The following is a description of a gene set: Human Gene Set: GOCC_DENDRITIC_TREE species: Homo sapiens The entire complement of dendrites for a neuron, consisting of each primary dendrite and all its branches., and this is the list of marker genes: BSN, AMIGO1, NPFF, CALB1, KIFC2, SHANK3, ABHD17C, RARA, FZD4, TRIM3, CNIH3, RACK1 (NCBI Gene Id 90938), TANC1, PAK1, GLRB, KCNH1, HTR2A, ATCAY, PPP1R9B, KCNB2, DAB2IP, GRIN2A, SARM1, IGF2BP1, KCNIP2, APBA2, TP63, DAGLA, LGI1, DGKI, DRP2, RGS12, TMEM266, SLC32A1, CHL1, CHRNA4, NR1D1, FEZ1, DIP2A, RHOA, TRPV1 (NCBI Gene Id 7442), GABRE, SYAP1 (synapse associated protein 1), TMEM222, EPHA8, CX3CR1, AKAP5, HTR7, CDKL5, BRINP2, RGS7, THY1, FCGR2B, BRINP3, ZDHHC5, MAST1, TNN, DBNL, BDNF, NECTIN1, KCNJ2, OPRM1, GABRA2, SLITRK2, PLEC, APOE, EPHA10, RGS8, ADORA2A, DHX36, OPRD1 (opioid receptor delta 1), C4A, SHISA9, STAT1, GIGYF2, SKOR1, RTN4RL2, FUBP3, SYN1, STRN4, RGS14, ATP2B2, HIP1R, AKAP9, EPHA4, FXR1, CLU, GAP43, SLC12A5, MME, GLRX5, CRHR2 (corticotropin releasing hormone receptor 2), SRGAP2, HTR1D, STRN, NRGN, KCND1, SOD1, GABRA4, ADORA1, BECN1, COMT, PLK3, PALMD, SYT11, ATP1A2, MARK2, OPA1, SRCIN1 (NCBI Gene Id 80725), PCDH8, CACNG3, NCS1, PRSS12, DTNBP1, RAB5A (NCBI Gene Id 5868), VSTM5, FZD3, LRIT1, XRN1, HRH4, ASIC1, SCGN, HTR5A, PPT1, RIN3, MT3, GNAZ, TMEM108, COBL, UCN, CAMK2N1, GRM6, MDGA1, ARC (NCBI Gene Id 53837), BRINP1, LRRC4, NDFIP1, CLSTN2, GABRA3, NLGN1, ZDHHC12, CNGA3, DLG4, TRAK2, PSEN1, ATXN1L (ataxin 1 like), MPP2, GRM7, HTR2B, ATP6AP2, PRR7, SHANK2, JPH4, NSMF, CHRNA7, HNRNPU, MAP1S, SLC9A5, EPHB6 (NCBI Gene Id 2051), KIRREL1, CPLX2, MAX, TMEM151A, KCNB1, MAP1B, ITGA8, GPHN, GRM2, PRKAA1, SLC6A6, STX4, GNRH1, ZC3H14, MARK4, CHRM2, ZMYND8, HTR2C, KCND3, WASF1, NECTIN3, ABL1 (ABL proto-oncogene 1, non-receptor tyrosine kinase), KLHL20, NTF4 (NCBI Gene Id 4909), GNAI2 (NCBI Gene Id 2771), ANKS1B, KCNA2, PENK, KIRREL3, ADORA3, DDN, EEF2K, BRD1, CPEB3, RPS6, ERO1A, MINK1, ADCY10, CPEB1, EPHA5, BCR, HRH2, HPCA, OPHN1, PPP1CA, ARHGAP44, FGF13, ZFYVE27, RIT2, GLRX3, SAMD4A (NCBI Gene Id 26078), NGF, KPNA1, TPGS1, MAPT, CHRM3, EPHB3, RCVRN, SIPA1L1, GRIK2, IFT57, SLC4A8, BAG2, CTTNBP2, IL6ST, GRID2, HCN3, AZIN2, LUZP1, ARHGAP32, CYBB, DRD4, HCN4, PTCHD1, CAPN2, RPH3A, NCDN, ARF4, ZNF804A, RAB8A, PURA, LZTS3, EPHA6, RTN4R (reticulon 4 receptor), CD3E, CNTNAP2, CALB2, EPHB2, SORBS2, FLNA, KCNC4, GCHFR, CCR2, IFT52, LZTS1, NSG2, CNR2 (NCBI Gene Id 1269), STRN3, PPP3CA, DNER, ACAD9 (acyl-CoA dehydrogenase family member 9), IL1RAPL1, PHAF1, NSG1, LHFPL4, DOCK10, GABRG2, ADGRB1, PSD, AVP, C4B (complement C4B (Chido/Rodgers blood group)), KCNC1, ELOVL5, GRIN1, FBXO2, KCNN2, CASC3, HTR1B, KIF1A, CPT1C, MAP1A, LRIT3, ELAVL4 (ELAV like RNA binding protein 4), SNX14, HCN1, EPHA3, PPP1CC, DRD1, SLC1A4, LYNX1 (Ly6/neurotoxin 1), ITSN1, NUMA1, GRM5, PI4K2A, GRM1, MAF1, SEPTIN4, DTNB, HSP90AB1, CAMK2A, RAC1, SYNDIG1, NEURL1, L1CAM, KLHL1, TTLL7, GPR179, LMTK3, CACNA1C, TACR3, PPP5C, MTOR, LRRK2, TENM2, PPFIA1, MTMR2, SLC8A2, HTT, CNIH2, KNDC1 (kinase non-catalytic C-lobe domain containing 1), TRPM5, GRIA1, LRFN3, GNG13, ASIC2, MARK3, GPR37, ITGB1, RAB17, ADCY9, UHMK1, GOPC, ALS2, CHRNA3, PTCH1, CRYAB, RELN, ADCY4, NCF1, NIN, ABI2, CAPRIN1, TRPC5, SEPTIN14, OPN4, GABRA6, ABHD13, FARP1, INSR, DNM3, GABRB1, TRAK1, TXNRD2, PRKAR2B, MPDZ, AMFR, GSK3A, ARFGEF2, PDLIM4, GRIP1, RBM3, INPP5A, BIN1 (bridging integrator 1), NTRK2, UBXN2A, KIFAP3, SACS, OSBP2, SEZ6, FZD5, KIF1B, CNNM1, SLC8A1, ELK1, SYNPO, CHRM1, INPP5J, GLRA1, MARK1, P2RX6, C9orf72, SEPTIN11, LAMA2, DNAJB1, APBA3, HOMER1, HSP90AA1, GIPC1, HTR1A, KIF5A, ABHD12, RGS7BP, APP, FYN, HTR4, GSK3B, MT-ND1, BMPR1B, SMO, BMPR1A, GLRA3, MAP2K1, RTN1, PTPRO, GPER1, GNB5, HRH1, NTRK1, KCNC2, GNB3, EPHB1, GRID1, RAB3IP, ARHGAP33, MAGI2, TMEM185A, HRH3, GABRA5, PTEN (phosphatase and tensin homolog), CRMP1, ARHGEF15, ABR, NRDC, RAP1GAP, SRSF10, SYT4, RANGAP1, LAMP5, STX3, PPP1R9A, CD2AP, GNAO1, UNC5C, GNG3, IFT20, GRIA3, INPP5F, LRP8, GABRD, FMR1, HTR1E, DRD2, GRIA2, GRM3, CPLX1, SLC17A8, MAP2, PRKCG, GABRG3, BPTF, P2RY1, N4BP3, KCND2, SHISA8, LPAR1, EPHA7, WDR47, TACR1, GRIA4, KCNIP1, ACTN2, DVL1, URI1, HOMER3, FLOT2, FAT3, TAOK2, PDE4B, IGSF9, ELFN1, HCN2, PTK2B, BAIAP2 (NCBI Gene Id 10458), DBN1, OPRK1, PPP2R1A, SEMA4F, MAP6, SPG11, SLC38A2, FRMPD4, TUBB3, CYBA, MAPK8IP1, STAU2, SAMD14, GPM6A, RPTOR, TSC22D4, PALM, CPEB4, PNOC, GABRG1, KCNE3, APBA1, PRNP, BNIP3, NSF, GABRB3, ATP7A, KIF5C, SORCS2, MYL7, GABRB2, HTR1F, MAPK8IP3, NLGN4X, EPM2A, HTR6, ADCY2, LRP2, MLPH, ADAM10, DMWD, SLC1A1, PRRT2, DSCAM, GRIK3, ADNP, SFPQ, LRP4, KCNK9, RAB27A, ABI3, AGO2, DIP2B, SLC4A10, HDAC6, CYP46A1, YKT6 (NCBI Gene Id 63236), SYNGAP1, CHRM4, PPFIA2, DCP1A, DYRK1A, RABGEF1, CACNG8, HNRNPAB, ZWINT, SLC5A7, KIF1C, RUFY3, SHISA6, ATF4, PREX1, GABRA1, HOMER2, KIF17, PLXDC1, NF1, GIT1, CDC42, EIF4A3, CFL1, MYH10, RBM8A, CTNND2, STAU1, MYO1D, LYPD6, KCNK2, EFNB2, CPNE6, MAPK8, SLC18A2, NEGR1, BGLAP, KIF3B, KCNC3, ITPKA, TPBG, MCRS1, ZNF385A, RPL28, SGCE, TANC2, PSD2, KIF5B, WFS1, CRIPT, NAP1L4, GRIPAP1, ABHD17A, GRIN2B, ABHD17B, ALCAM, CDK5, ANK3, PRKAA2, MAGEE1, TRAPPC4, BACE1, SLC8A3, CLCN2, SHANK1, KIF21B, ABITRAM, NLGN2, DPYSL5, KCNA4, ROGDI, SLC30A1, ATXN10, KIF21A, CTTN, KCNA1, HAP1, TRIM9, NTF3, GABBR1, NECAB2, NGFR, NOS1, PDYN, CLSTN3, CRHBP, NTSR1, CHRM5, BMPR2, SHISA7, APOD, KCNK1, ADCY8, PLK2, CDK5R1, NGDN